Given this list of marker genes NR1H4, FGFR4, VDR, DGKQ, ALAS1, GPBAR1, ABCB4, here is a description of the gene set: Human Gene Set: GOBP_RESPONSE_TO_BILE_ACID studied in species Homo sapiens Any process that results in a change in state or activity of a cell or an organism (in terms of movement, secretion, enzyme production, gene expression, etc.) as a result of a bile acid stimulus.